The following is a description of a gene set: Genes predicted to be targets of miRBase v22 microRNA hsa-miR-4727-3p in miRDB v6.0 with MirTarget v4 prediction scores > 80 (high confidence targets). from publication Chen Y, Wang X (PMID 31504780) studied in species Homo sapiens Human Gene Set: MIR4727_3P, and this is the list of marker genes: KRTCAP3, ZNF214 (NCBI Gene Id 7761), SLC22A15, ZNF484, KATNBL1, CLDND1, B4GAT1, OTUD4, OR7A5, MMD (monocyte to macrophage differentiation associated), ARHGAP33, C22orf23, RPGRIP1L, ARL15, EGFR, IRAK2, TMCC1, AFAP1L2, DDIT4L, DISC1, RAP1A, FADS2, ZMYM4, OAS2, WDFY3, NEK2 (NCBI Gene Id 4751), TRIL, USP48, APLP2, DENND1B, FUCA2